The following is a description of a gene set: from publication Bonilla WV, Fröhlich A, Senn K, Kallert S, Fernandez M, Johnson S, Kreutzfeldt M, Hegazy AN, Schrick C, Fallon PG, Klemenz R, Nakae S, Adler H, Merkler D, Löhning M, Pinschewer DD (PMID 22323740) Pathogen-associated molecular patterns decisively influence antiviral immune responses, whereas the contribution of endogenous signals of tissue damage, also known as “damage-associated molecular patterns” or “alarmins”, remains ill-defined. We show that interleukin-33 (IL-33), an alarmin released from necrotic cells, is necessary for potent CD8+ T cell (CTL) responses to replicating, prototypic RNA and DNA viruses in mice. IL-33 signaled through its receptor on activated CTLs, enhanced clonal expansion in a MyD88-dependent, CTL-intrinsic fashion, determined polyfunctional effector cell differentiation and was necessary for virus control. Moreover, recombinant IL-33 augmented vaccine-induced CTL responses. Radio-resistant cells of the splenic T cell zone produced IL-33, and efficient CTL responses required IL-33 from radio-resistant cells but not from hematopoietic cells. Thus, alarmin release by radio-resistant cells orchestrates protective antiviral CTL responses. studied in species Homo sapiens Human Gene Set: GSE34392_ST2_KO_VS_WT_DAY8_LCMV_EFFECTOR_CD8_TCELL_UP Genes up-regulated in P14 CD8+ T cells: ST2 knockout versus wildtype., and this is the list of marker genes: ARHGEF18, DOCK11, ABCG1, GRAMD4, ZNF8, ZFP36L2 (ZFP36 ring finger protein like 2), LYL1, DUSP22, C5orf34, CYP27A1, PPARG, SLC44A2, MKNK2, RPS6KA1, CHST12, PDXK, RALGAPB, ARHGAP19, ZCCHC24, GPR155, ZBED4, SRPK2, GYG1, OPLAH, RASA3, CORO7 (NCBI Gene Id 79585), FOXO3, FBXO5, FGD2, TP53INP1, AIMP1, NATD1, TCF12, AAGAB, CNPY4, ZNF414, ITSN1, NOTCH2, KIF21B, IL6R, C1orf21, CDK19, RPL35, TRIM14, IMP3, DPY19L1, NUMA1, KIF23, ZNF362, POLD1, ENC1, POLR2E, EIF3H, SMC6, RCBTB2, PDE7B, TXNIP, TXNDC16, ARHGAP9, IKBIP, DPYSL2, TMUB2, CXCR4, TBC1D10C, SKP2, EHD4, PRKAG2, ABHD15, CAMK2G, INPP5D, GPD1L, TPRG1L, NANP, LRRC1, TUBGCP5, RDH14, MAF, SEPTIN3, CBX4, P2RX7, ADD3, RAB11FIP5 (RAB11 family interacting protein 5), CRYZL1, FRG1, ARHGAP6, ARL6IP4, DEPDC5, LPAR6, POLR2A (RNA polymerase II subunit A), TUSC1, IDH3G, HEY1, MRFAP1L1, FAM217B, ITPRIPL2, CMBL, CNOT8, CTBP1, TUT4, RERE, SVIL, DNA2, PDCD4, KLHL6, SLC50A1, TPCN1, HPCAL1, TIMM21, RASL11B, PCMTD2, ANKFY1, CDCA7L, NDUFA6, SLBP, NHSL1, EEF2K (eukaryotic elongation factor 2 kinase), ADISSP, MAN2A2, EIF4G3, GRK6, ESYT1, NEURL2, UBE2T, RPL27, ECH1, MPPE1, PDPK1, GARS1, KDELR1, GPR160, NCOA1, TMEM154, MS4A6A, SOCS6, TNFAIP8L2, ANKRD44, HP1BP3, BUB3, SLC26A11, WDSUB1, PRPS2, SNX27, HEPACAM2, L1CAM, SASH3, STARD9, RPA3, MBLAC2, PPT1 (NCBI Gene Id 5538), CTDSP2, SLC35E3, SAAL1, HJURP, DIPK1A, ZNF707, RIPOR2, FAM117B, BMF (NCBI Gene Id 90427), PHF14, SSH2, ITPR1, RELL1, SNX30, UQCC5, SKI, MSRB1, OTULINL, DHX16, CARD11, GTF3C1, PIKFYVE (NCBI Gene Id 387568), PRAM1, PAOX, YPEL2, TEF, THBD, VDAC1, LPIN1, ANP32A, OSBPL11, INTS6L, RFC1, SESN1, PDLIM2, DYNLT1 (NCBI Gene Id 6993), PPP2R5C, SLCO2B1, MRPL24, SH2D1B, NRIP1, TMEM161A, SMIM5, RNASET2, NCOA3, LPXN, ARHGAP39, TEP1, ANGPTL4, HMGCL, RASA1